Given this list of marker genes ADCY5, ADCY9, ADCY2, PRKAR1A, CALM1, ADCY7, NBEA, PRKAR2A, ADCY1, ADCY6 (NCBI Gene Id 23320), ADCY8, PRKACA, PRKAR1B, PRKACG, ADCY4, PRKACB, ADCY3, PRKAR2B, here is a description of the gene set: part of: PKA-mediated phosphorylation of CREB studied in species Homo sapiens Reactome Pathway: PKA activation A number of inactive tetrameric PKA holoenzymes are produced by the combination of homo- or heterodimers of the different regulatory subunits associated with two catalytic subunits. When cAMP binds to two specific binding sites on the regulatory subunits, these undergo a conformational change that causes the dissociation of a dimer of regulatory subunits bound to four cAMP from two monomeric, catalytically active PKA subunits.